The following is a description of a gene set: Spermatozoa genes, based on mouse models with male reproductive defects. from publication Matzuk MM, Lamb DJ (PMID 18989307) studied in species Mus musculus Reproduction is required for the survival of all mammalian species, and thousands of essential 'sex' genes are conserved through evolution. Basic research helps to define these genes and the mechanisms responsible for the development, function and regulation of the male and female reproductive systems. However, many infertile couples continue to be labeled with the diagnosis of idiopathic infertility or given descriptive diagnoses that do not provide a cause for their defect. For other individuals with a known etiology, effective cures are lacking, although their infertility is often bypassed with assisted reproductive technologies (ART), some accompanied by safety or ethical concerns. Certainly, progress in the field of reproduction has been realized in the twenty-first century with advances in the understanding of the regulation of fertility, with the production of over 400 mutant mouse models with a reproductive phenotype and with the promise of regenerative gonadal stem cells. Indeed, the past six years have witnessed a virtual explosion in the identification of gene mutations or polymorphisms that cause or are linked to human infertility. Translation of these findings to the clinic remains slow, however, as do new methods to diagnose and treat infertile couples. Additionally, new approaches to contraception remain elusive. Nevertheless, the basic and clinical advances in the understanding of the molecular controls of reproduction are impressive and will ultimately improve patient care. Human Gene Set: MATZUK_SPERMATOZOA, and this is the list of marker genes: PRND, PGS1 (NCBI Gene Id 9489), AGFG1, SLC12A2, TCF21, VIPR2, HSPA4L, SLC9C1, CENPB, SPAG9, TSSK6, ROS1, AFF4, TAF7L, B4GALT1, CLGN, GOPC, SPAG6, JAM3, LRP8, CGA, PIWIL1, POLG, TGFB1, FNDC3A, CPLX1, PACRG, ADAMTS2, BBS1, SEPTIN4, CSNK2A2, CSTF2T, ACR, FHL5, CADM1, CNOT7, CFAP221, INPP5B, NPHP1, SIRT1, TALDO1, TNP2, TEKT3, WIPF3, GAMT, PEBP1, AGTPBP1, ATP2B4, BBS2, GAPDHS, TEKT2, RXFP1, ADAD1, CREM, SPMAP2, NIPA1, ACE, PLA2G4C, PRM1, RBMXL2, CAMK4, PCSK4, SPAG16 (sperm associated antigen 16), RXRB, TSN, ZPBP, STRBP, TNP1, NECTIN2, TEKT4, ADCY3, CIB1 (NCBI Gene Id 10519), GDI1, PLCB1, GBA2, PRM2, MTHFR, AKAP4, LDHC, VDAC3, PLCD4, ADCY10, APOB, DNAH1, BUB1, SMCP, CD81, ADAM2, SPAM1, BBS4, NSUN7, SH2B1, EGR4, SMPD1, CD59, PRKACA, GMCL1, RASIP1, PLTP, PGAP1, BRDT, HOOK1, AHR, MMEL1 (membrane metalloendopeptidase like 1), KLHL10, PRKAR1A, ZPBP2, POLD4, SELENOP, JUND, ADAM3A, MFGE8, SPEM1 (spermatid maturation 1), ARL4A